The following is a description of a gene set: The 8p11-12 chromosome region is one of the regions most frequently amplified in breast carcinoma (10-15% of cases). Several genes within this region have been identified as candidate oncogenes, as they are both amplified and overexpressed. However, very few studies have explored the role of these genes in cell transformation, with the aim of identifying valuable therapeutic targets. An analysis of comparative genomic hybridization array and expression profiling data for a series of 152 ductal breast carcinomas and 21 cell lines identified five genes (LSM1, BAG4, DDHD2, PPAPDC1B, and WHSC1L1) within the amplified region as consistently overexpressed due to an increased gene copy number. The use of small interfering RNA to knock down the expression of each of these genes showed the major role played by two genes, PPAPDC1B and WHSC1L1, in regulating the survival and transformation of two different cell lines harboring the 8p amplicon. The role of these two genes in cell survival and cell transformation was also confirmed by long-term knockdown expression studies using short hairpin RNAs. The potential of PPAPDC1B, which encodes a transmembrane phosphatase, as a therapeutic target was further shown by the strong inhibition of growth of breast tumor xenografts displaying 8p11-12 amplification induced by the silencing of PPAPDC1B. The oncogenic properties of PPAPDC1B were further shown by its ability to transform NIH-3T3 fibroblasts, inducing their anchorage-independent growth. Finally, microarray experiments on PPAPDC1B knockdown indicated that this gene interfered with multiple cell signaling pathways, including the Janus-activated kinase-signal transducer and activator of transcription, mitogen-activated protein kinase, and protein kinase C pathways. PPAPDC1B may also potentiate the estrogen receptor pathway by down-regulating DUSP22. from publication Bernard-Pierrot I, Gruel N, Stransky N, Vincent-Salomon A, Reyal F, Raynal V, Vallot C, Pierron G, Radvanyi F, Delattre O (PMID 18757432) Genes down-regulated in ZR-75-1 cells (breast cancer, amplified 8p11-12 region) upon knockdown of PPAPDC1B by RNAi. studied in species Homo sapiens Human Gene Set: BERNARD_PPAPDC1B_TARGETS_DN, and this is the list of marker genes: ACOT6, PRLR, ZNF703, SUSD4, ZMIZ1, SYT13, PROSER2, ARHGAP45, TBC1D2, PPARA, FAM66D, STC2, PTPRG, PLCE1, SH3BGRL2, TFF3, PRR7, SPRED2, ADD3, THBS1, GLDC, NUTM2A-AS1, DPY19L3, IGFBP5, GPR153, HIP1, RARA, BMS1P14, NAV1, SH3BP2, NSD3 (NCBI Gene Id 54904), KCNK5, GATAD2A, MACC1, FBXO32, IFT122, HDAC4, SEL1L3, FGFR2, MAPKAPK3, CISH, SCAMP1, RAP1GAP, STC1 (NCBI Gene Id 82914), HSD17B1-AS1, AP3M2, TMCC1, FAR2, GSTM4, RHOF, MXI1, ITGAL, IL6ST, KIF5C, MT1X, SERPINA1, NSF (NCBI Gene Id 4905), CALM1, PLPP5, RCAN1